The following is a description of a gene set: Mouse Gene Set: GOBP_DEOXYRIBONUCLEOSIDE_MONOPHOSPHATE_METABOLIC_PROCESS studied in species Mus musculus The chemical reactions and pathways involving a deoxyribonucleoside monophosphate, a compound consisting of a nucleobase linked to a deoxyribose sugar esterified with phosphate on the sugar., and this is the list of marker genes: Shmt1, Pnp, Nt5c2, Ada, Dhfr (dihydrofolate reductase), Dctd, Adk, Tk1, Dnph1, Uox, Nme2, Nt5c, Cda, Dpys, Tyms (thymidylate synthase), Shmt2, Nme1, Dck, Dguok, Tk2, Nme3, Gda, Upb1, Nt5c3, Nt5m, Urah, Dpyd, Dut, Urad, Nt5c1a, Xdh, Tymp, Upp2, Upp1, Guk1